Given this list of marker genes ATP5MJ (NCBI Gene Id 9556), ATP5F1C, MICOS13, ATP5PO, ATP5PB (NCBI Gene Id 515), ATP5MF, CHCHD3, ATP5PF, TMEM11, APOO (apolipoprotein O), DMAC2L (NCBI Gene Id 27109), APOOL, ATP5F1E (NCBI Gene Id 514), MT-ATP6, HSPA9, MICOS10, ATP5MC3, ATP5F1A, CHCHD6, ATP5ME, SAMM50, ATP5MG, MTX1, ATP5F1D (NCBI Gene Id 513), ATP5MK, MTX2, ATP5MC1, DNAJC11, MT-ATP8, ATP5MC2, ATP5PD, IMMT, ATP5F1B, here is a description of the gene set: Cristae formation Human Gene Set: REACTOME_CRISTAE_FORMATION studied in species Homo sapiens